The following is a description of a gene set: Abnormality of glucose homeostasis. Abnormal glucose homeostasis species: Homo sapiens Human Gene Set: HP_ABNORMAL_GLUCOSE_HOMEOSTASIS, and this is the list of marker genes: APC2 (NCBI Gene Id 10297), SLC40A1, IGFALS, SLC7A14, SLC37A4, MAFA, PAPPA2 (NCBI Gene Id 60676), CELA2A, ATIC, KCNQ1, CARS1, COX10, HLA-DQB1, BBS10, PLAG1, PHKB, CNGA1, MT-ND3, FXN, MTOR (mechanistic target of rapamycin kinase), FSCN2, CC2D2A, PRPF3, HJV, PRKACA, SOX3, TCF7L2, IFIH1, MYT1L, HAMP (NCBI Gene Id 57817), TFAM, PRPH2, KDM1A (lysine demethylase 1A), PAX6, ROBO1, PAX4, PCYT1A, RHO, SLC25A4, DNMT1, MRPL39, POR, IFT27, TEFM, SEMA4D, MMP14, MRPS7, DHDDS, GLI2, ACADM (NCBI Gene Id 51779), NDUFAF6 (NCBI Gene Id 137682), FBP1, SH2B1, ZNF668, TMEM126B, YIPF5, TRAPPC11, SPATA7, GLIS3, NR2E3, SLC1A1, HADHB, LHX4, HERC1, HADHA, MT-CO2, MT-TV, NOP10, POMGNT1 (NCBI Gene Id 55624), AIRE, COX11, NBAS, DIS3L2, PNPLA6, NDUFA11, PAK1, BUD23, IGHG2, DNAJC21, EYS, MEN1, LEMD3, PWRN1, ITPR3, OTC, IARS1, CPA1, LIPE, MRAP, NUBPL, PDE6A (NCBI Gene Id 5145), RAC1, CORIN, IL2RA, PRSS2, NDUFS6 (NADH:ubiquinone oxidoreductase subunit S6), HNF1B, GALK1, IGF2, PARN, POLA1, ACADVL, NDUFB9, ALG12, PREPL, USB1, NDUFAF1, HSD11B1, STX5, ALMS1, CTC1, TERC, IFT74, GTF2IRD1, ZMPSTE24, GYG1, MMAB, MERTK, NDUFS1, RP1L1, GCGR, KCNE3, GK, DCAF17, RRM2B, NDUFAF4, FOXP3, NDUFAF3, DHX38, EDA, YARS1, TCF4, NDUFS4, NDUFA6, RABL3, ZNRF3, YY1, MT-ND4, ATM, G6PC1, POMC, PROP1, CYP19A1, TREX1 (three prime repair exonuclease 1), IMPG2, RETN, CLRN1, HTRA2, WRAP53, UQCC3, MTX2, WFS1, POU1F1 (NCBI Gene Id 5449), PET100, KIAA1549, LRBA, PLCD1, TBL2, HFE, MAK, TIMMDC1, NDUFB10, KLHL7, POGZ, NARS2, MT-ATP8, GPD2, PRSS1, STAT3, TTC7A, FARSB, RNF125, PRORP, CPT1A, TRPV6, ZNF513, LIG4, TRIM32, CFAP418, MLYCD, SLC19A2, MT-TS2, ADA2, SBDS (SBDS ribosome maturation factor), MAGEL2, LHX3, MT-ND2, CLIP2, SIN3A, XRCC4, PRPF6, ACAT1, MT-CO1, POC1A (NCBI Gene Id 25886), GCK, GUCA1B, MEF2A, DUT, NR3C1, BBS5, CP, ATP7A, RTEL1, RNASEH2C, PPP1R3A, FOXA2, PRKAR1A, KDM6A, PLIN1, CDON, CRB1, PTEN, EHHADH, ENPP1, TTPA, MMUT, APPL1, MTO1, QRSL1, SPI1, EIF2AK3, FOXRED1, NSMCE2, HADH, ZNF408, LRAT, FOCAD, FKBP6, RNU7-1, MT-TL1, UBR1, NEUROG3, SHPK, BBS7, FAH, ELN, SLC5A2, MT-TK, TANGO2, IMPG1, ETFDH, HR, PCK1, IGKC, HBB, INSR, LIMK1, ALAS2 (NCBI Gene Id 90735), CYP21A2, BLK, CNGB1, RIMS2, UCP2, CA5A, NNT, MPC1, PHKA2, PWAR1 (NCBI Gene Id 8122), STAT6, HMGA2, SAMD9, DNASE2, KCTD1, SUCLG1 (NCBI Gene Id 8802), NDUFS7, LIPC, HMGCL, HGSNAT, OPA1, GLI3, FBN1, STAR, SLC22A5, CAV1, FUT8, ELMO2, BEST1, CCDC28B, MT-ND1, DGUOK (NCBI Gene Id 1716), ADAR, CFTR, REEP6, SLC3A1, AGL, NDUFS8, GPC4, COX16, TFG, MOG, SECISBP2, GLUD1, PALB2 (NCBI Gene Id 79728), METTL27, SERAC1, SLC12A3, BAZ1B, MEG3, EIF4H, BCKDHA, SLC5A1, MLXIPL, LEPR, ABCA4, RBP3, NDUFS2, TRMT5, CEL, CLCNKB, TLR8, GCDH, PROK2, IDH3B, WDPCP, PEX6, SCO1, LEMD2, LZTFL1, SLC34A1, CLPB, CTLA4, SARS2, SMAD4, USH2A, CNOT1, IFT88, GMPPA, IGF2BP2 (NCBI Gene Id 10644), FOS, ADRA2A, PCCB, DNAJC19, BBS4, NPAP1, PRPF31, TKT, RTL1, CIDEC, GLYCTK, VPS37D, TMEM270, PCBD1, KLF11, AFF4, DLK1, MT-CYB, ACSL5, GABRA3, BMP2, CYP11A1, SGPL1, NDN, NPM1, NPHP1, BCS1L, MCCC2, STOX1, PRCD, RP9, ALDH7A1, NDUFB11, GPR101, ACAD8, PPP1R15B, ITCH, FOXP1, TERT, DNAJC30, SAG, ARL6, PRPF8, AR, POLD1, RP1, ACADSB, RLBP1, SCN4A, ERCC6, GATA3, SLC16A1, LRPPRC, MAPK8IP1, HYMAI, MKS1, PNPLA2, NEUROD1, DOLK, TYMS, SNORD115-1, HLA-DRB1, LMNB2, PTF1A, FOXC2, GTF2I, TRPM3, BBS9, MRPS2, AUH, DKC1, STUB1, SCLT1, MRPS28, NDUFV1, PCK2, HLA-DQA1 (major histocompatibility complex, class II, DQ alpha 1), WT1, RP2, PPM1B, CTNNB1, GPR161, IARS2, STX1A, MKRN3, ESR1, AKT2, PCARE, IL6, CTDP1, NDUFB3, PEX1, GTF2IRD2, RFC2, CIC, PSTPIP1, APOE, RPGR, MICOS13, SNRPN, TINF2 (TERF1 interacting nuclear factor 2), PDE6B, IDH3A, RNASEH2A, MTNR1B, NFKB2, EBP, AMACR, FAM161A, BSCL2, PDX1, KRAS, IL18BP, TFE3, COG7, RFX6, SNRNP200, PC, PHKG2, PALLD, HMGA1, PTPN22, INS, LSM11, BBIP1 (BBSome interacting protein 1), EIF2S3, DLD, KCNJ18, NDUFA1, MC4R, CTRC, MICU1 (NCBI Gene Id 51415), GYS2, PDE6G, FLT1, ZFYVE26, AEBP1, CRX, PI4KA, GNAS, GFRA1, GFM2, PROKR2, PPARG, HYOU1, CDHR1, TULP1, RDH12, IER3IP1, ATP5F1D, ROM1, GATA6, IGF1R, MSL3, PYGL, MMP2, ADCY3, IRF4, PIK3R1, PMM2, FGF20 (NCBI Gene Id 26281), LEP, ABCC8, HESX1, POLG2, GOSR2, TTC8, TOPORS, HRAS, NDUFV2, PROM1, ABCB4, COG8, IFT140, CASR (NCBI Gene Id 846), PSMB8, BRCA2, BBS1, KHK, NR1H4, AHI1, SEMA4A (NCBI Gene Id 64218), DBH, LRP6, KIZ, MT-TQ, CDH23, ACBD6 (NCBI Gene Id 84320), MADD, PCSK1, SIM1, MPI, PHLDB1, CACNA1C, LMF1, PCCA, ARHGEF18 (Rho/Rac guanine nucleotide exchange factor 18), PPP2R5D, SDCCAG8, CNBP, ETFB, GRB10, NAB2, PNPO, DNM1L (dynamin 1 like), PLAGL1, LHX1, NDP, NDUFAF8, NHP2, MST1, FMR1, ITGA8, KCNQ1OT1, BLM, TBX19, NOTCH3, RNASEH2B, MIA3 (MIA SH3 domain ER export factor 3), GH1, IGF1, IFT172, EDA2R, GLRX5, HNF1A, MFN2, CTNS, SLC52A1, WDR11, THRB, SLC29A3, PYGM, MT-CO3, IRS1, SNORD116-1, GCSH, GALT, ASXL2 (ASXL transcriptional regulator 2), PLAAT3, CISD2, RRAGC, MT-ATP6, KMT2D, POLR1A, GATB, WNT9B, CDKN1C, ARL2BP, ARMC5, PLPBP, PCNT, POLG, SLC2A2, STAT1 (signal transducer and activator of transcription 1), CBLB, PTRH2, DNAJC3, PTPN1, RGR, OCA2, GPC3, AIP (NCBI Gene Id 9049), BBS12 (Bardet-Biedl syndrome 12), ATRX, CYC1, DYRK1B, NDUFAF2, PEX10, AGBL5, ARL3, MC2R, ODC1, BBS2, PDE4D, SLC25A36, SLC25A20, USP8, CERKL, MT-ND5, GJB3 (gap junction protein beta 3), ZFP57, NSD1, MT-TC, HERC2, SMPD4, PRPF4, UQCRB, AHR, OFD1, DMXL2, MT-TF, CPE, TXNRD2, KDSR, NAF1, NRL, GATM, HMGCS2, MT-ND6, MT-TW, MT-TE, SLC30A8 (solute carrier family 30 member 8), BRAF, EFL1, ZBTB20, SMC5, CDKN2A, MKKS, CDKN1B, AAAS, LMNA, HNF4A, AGPAT2, GATC, UQCRC2, UQCRH, ALDOB, GHR, ACADS, CAT, WARS2, MCCC1, NFS1, BRCA1, NCF1, SAMHD1, STIM1, POLR3A, KCNJ11, ACSF3, CYB561, SNIP1, SCAPER, PHKA1, GHSR, WRN, CEP19 (centrosomal protein 19), NEK2, PDCD1, IRS2, HSD3B2, H19, GJA1, CACNA1S, GREB1L, TRMT10A, TUB, BMP6, DDC, CPT2, NDUFAF5, RPE65, ETFA, IMPDH1, NDUFS3, MPV17, CA4, MANF, PRKAG2, RET, USP48, ACAD9, TWNK, CAMKMT, PGM1, HSD17B10, APOA5, MT-TH, OTX2, TP53, MMACHC, SPINK1, CAVIN1, GJB4, CEP290, GPR35